The following is a description of a gene set: species: Mus musculus Any process that stops, prevents, or reduces the frequency, rate, or extent of leukocyte chemotaxis. Mouse Gene Set: GOBP_NEGATIVE_REGULATION_OF_LEUKOCYTE_CHEMOTAXIS, and this is the list of marker genes: Dusp1, Stap1, Padi2, Slit2, Slamf8, Klrk1, Nbl1 (NBL1, DAN family BMP antagonist), Tnfaip6, Mif, Gpr18, Hc, Rin3, Dpp4, Cyp19a1, C5ar2, Mmp28, Ccl12, Grem1, Ccn3